Given this list of marker genes Cdc27, Anapc2, Cdc20, Cdc23, Cdc16, Uba52 (ubiquitin A-52 residue ribosomal protein fusion product 1), Cul1, Ubb, Cdk2, Ube2s, Anapc10, Ube2e1, Anapc5, Plk1, Bub1b, Ube2d1, Skp1, Anapc4, Fbxo5, Ubc, Anapc7, Uba52rt, Cdk1, Anapc1, Ccna1, Mad2l1, Ube2c, Bub3, Ccna2, Anapc11, Anapc15, Fzr1, Anapc16, Cdc26, Rps27a, Ccnb1, here is a description of the gene set: Mouse Gene Set: REACTOME_REGULATION_OF_APC_C_ACTIVATORS_BETWEEN_G1_S_AND_EARLY_ANAPHASE studied in species Mus musculus Regulation of APC/C activators between G1/S and early anaphase